The following is a description of a gene set: from publication Chen Y, Wang X (PMID 31504780) Mouse Gene Set: MIR_221_5P Genes predicted to be targets of miRBase v22 microRNA mmu_miR_221_5p in miRDB v6.0 with MirTarget v4 prediction scores > 80 (high confidence targets). species: Mus musculus, and this is the list of marker genes: Tfap2b, Homer1, Tecrl, Hdac6, Elmo2 (engulfment and cell motility 2), Golga1, Nxf1, Smim10l1, Yaf2, Ttyh2, Tmem201 (NCBI Gene Id 52277), Apc2, Opn3, Dnmt3l, Rbm4b, Klrb1b, Irf4, Plekhm2, Togaram1, Mex3b, Trim59, Mtbp, Nt5c3, Klhl24, Plekhd1, Gprc5a, Gatad2a, Kdm6a, Lpar1, Mcmbp, Atp1b1, Sorcs1, Cdc42bpa, Chic1, Ube2ql1, Rem1 (rad and gem related GTP binding protein 1), Slc6a15, Tmod1, Pipox, Trabd2b, Nrip3, Ppp1r42, Mbnl1, Chic2 (NCBI Gene Id 74952), Zbtb33, Cops7a, Dolpp1, Cmtr1, Map3k20, Camta1, Ubl4a, Gfus, Cplx2, Mtmr2, Slc6a17, Avl9, Serpinf2, Ralbp1, Odf2, Sdc2, Trp63, Ubfd1, Kmt2a, Ptp4a2, Fam78b, Vps52